Given this list of marker genes ATP6V1E1, CTBP1-AS, GNS, ZFAND4, SMARCC2, SLC25A29, ARID3B, HERC4, PTMA, LAMP2, AP1AR, UBE2V2, LRP4, SNAP29, CCL28, GLCE (NCBI Gene Id 90998), POLR1E, SNHG6, PNISR, PPP6R2, DTNBP1, IL5RA, SGSH, TMUB2, CHMP2B, SGTB, TNFAIP8, SUZ12P1, HEXB, RBM28 (NCBI Gene Id 55131), PRXL2B (NCBI Gene Id 127281), ZMYM3, ATP2B1, TOLLIP, MKRN2, ZBTB25, GNPDA1, NUMA1, UBL7, ATP6V0C, COX7A2L, NACA4P, PLCXD1, MOSPD1, EPB41, FCRL4, SAFB2, FNIP2, GNPTG, GPI, IKZF3, AKAP10, ZFP62, CFDP1, OTUD3, HIPK2, PIK3CB, CERT1, ADH1C, LONP1 (NCBI Gene Id 9361), C7orf50, GABARAP, ZNF280B, SLC25A26, PRPF8, NAP1L1, CGAS, TMEM267, SLC26A11, HDAC6, IGF2R, ATP6AP1, SP2, PPFIA4, DRAM2, CD63, EDEM1, TRAPPC2L, CEPT1, FAM13A, LRRC42, CLCN7, CLN3, ABCC3, GBE1 (NCBI Gene Id 2632), LINC01165, NPL, HIBADH, CRY1, DVL2, EPG5, POU3F2, TBC1D2, EIF1B, PHAF1, SNAPC1, GDI1, SNX3, NTAN1, PARP6, VAC14, AP3S1, PIK3IP1, SYNE3, ZBTB20, TPST2, ZEB2, LILRA2, RAB7A, PABPN1, UBE2D2, NISCH, CYSTM1, ASAH1, POU2F1, LEP, ST13, ORAI3, DENND1A, FNDC3A (NCBI Gene Id 22862), SEC61A2, PIK3C2B, PPARA, ABCA5, NPTN, TMC6, CBFA2T2, TBCA (tubulin folding cofactor A), CDKL3, NBPF1, USP22, CKS1B, SLC31A1, ZNF702P, SMAD2, OPLAH, PAG1, FCGR2B, CAST, SMG1, TMEM140, GPR158, PDCD7, BICDL2, RRAGD, NSMCE2, SMDT1, DERL1, HEXA, ADAMTS20, COLEC12, COX5A, MIF, RPS6KA2, MFSD14A, RRAGC, CXCL11, RNASEK, TRPM7, FUT11, PABPC4L (poly(A) binding protein cytoplasmic 4 like), RIMOC1, GDNF (glial cell derived neurotrophic factor), FIG4, BRI3, TNFRSF14, ATP6V0E1, PHC1, CD300A, M6PR, ACAT2 (acetyl-CoA acetyltransferase 2), RHEB, TMEM144, KLHL36, MROH1, VPS37A, ARHGAP26, UMOD, ZSCAN22, PHF1, NPC2, IL18BP, HSD17B4 (hydroxysteroid 17-beta dehydrogenase 4, NCBI Gene Id 3295), ZNF395, TMA16, MXI1, FCRLB, HCAR3, TBXT, AKIRIN2, LINC00847, SAP30, RBPJ, MEA1, FAM50A, here is a description of the gene set: from publication Schwartz JT, Bandyopadhyay S, Kobayashi SD, McCracken J, Whitney AR, Deleo FR, Allen LA (PMID 22986450) We demonstrated recently that both constitutive and FAS-triggered apoptosis of human neutrophils are profoundly impaired by Francisella tularensis, but how this is achieved is largely unknown. To test the hypothesis that changes in neutrophil gene expression contribute to this phenotype, we used human oligonucleotide microarrays to identify differentially regulated genes in cells infected with F. tularensis strain LVS compared with uninfected controls. In order to examine the effect of F. tularensis on the neutrophil transcriptome, we performed microarray expression analysis on human neutrophils treated with F. tularensis subsp. holarctica live vaccine strain (LVS). Genes down-regulated in comparison of control polymorphonuclear leukocytes (PMN) at 12 h versus PMN treated with F. tularensis vaccine at 24 h. Human Gene Set: GSE37416_12H_VS_24H_F_TULARENSIS_LVS_NEUTROPHIL_DN studied in species Homo sapiens